The following is a description of a gene set: studied in species Mus musculus Mouse Gene Set: GOBP_REGULATION_OF_RECEPTOR_RECYCLING Any process that modulates the frequency, rate, or extent of receptor recycling., and this is the list of marker genes: Nsf, Psen1, Arap1, Ap1ar, Nsg1, Inpp5f, Vamp3, Gria3, Dab2, Agtr1a, Pcsk9, Ece1 (NCBI Gene Id 230857), Tbc1d16, Ache, Snca, Ramp3, Eps15, Psen2, Scrib, Bves, Lamtor1, Trat1, Kif16b, Gria1, Anxa2, Optn, Chmp5, Gria2, Rab29, Ldlr